The following is a description of a gene set: Genes having at least one occurrence of the motif NTGACTCAN in the regions spanning 4 kb centered on their transcription starting sites. This matches the JUN transcription factor binding site V$AP1_Q6_01 (v7.4 TRANSFAC). studied in species Homo sapiens Human Gene Set: AP1_Q6_01, and this is the list of marker genes: GJB3, NFRKB, SYNGR1, ABHD4, CSMD3, SPATA16, ESRRG, ANK3, SDCBP, ABCA2, PSMD7, AXIN2, MAP7D1, PDAP1, SYN1, DYRK1A, ASS1, SMPX, DTNA, AKT1S1, BRD2, TAGLN2, SNCG, STARD13, NRN1L, PSMA3, GAPDH, NFATC4, RCAN2, ITPKC, DCTN2, ZFYVE9, PDGFRB, S100A5, SPTA1, ITM2B, CAB39, ZNF207, GAST, KDM3A, PRSS22, PSMD2, MAGED1, TBC1D17 (NCBI Gene Id 79735), FBXO44 (F-box protein 44), LONRF3, IQCF1, PPP1R15A, LINC02908, LMNA, LAPTM5, HCLS1, ABCB6, CTNNAL1, GABBR1, RBBP7, KCNH2, ELK3, SV2A, NR0B2, EYA1, SCEL, IL9, RAB30, TOB1, UBE3A, PSMD12, SBSN, TRAPPC3, BUD31, VAT1, RNF144B (ring finger protein 144B), IGSF8, RAP1GAP2, DMPK, C1QTNF8, MCTP1, ADAMTSL1, ATP6V1A, TIAL1, PSME4, TENM3-AS1, MPRIP, LRRN4CL, DDIT3, RPL23A, KBTBD8, RIMS1, UBQLN1, LMOD3, PITPNC1, GIT2, CRYGS, AP2A2, HOXA11, ALDOA, LAMC1, TEX19, HSPA9, PLA2G2E, MAP4K5, MPV17, ASB5, EPHA2, VAPA, PI15, HSPG2, CLC, KCNA2 (potassium voltage-gated channel subfamily A member 2), GIT1, DIAPH1, GJA1 (NCBI Gene Id 7953), LPP, CAPN6, ZNFX1, RGS2, CASK, SNPH, DCN, ZBTB43, RTL9, ZNF771, PTPRR, LRRC2, MYOZ2 (myozenin 2, NCBI Gene Id 53348), AK5, NDUFA13, MMP19, DCLK1, PHLDA2 (NCBI Gene Id 7262), ANKRD22, CNTD1, NRDC, UCN2, KLK12, TRPV3, HSPB7, FERMT3, TNXB, PKN3, SCRN1, IRAK1, FGF9, ORAI1 (ORAI calcium release-activated calcium modulator 1), TUBA4B, CLSTN3, ROCK2, PPP2CA, KRT25, SMARCA2, EFNA1, PCDH9, PKP3, KRT86, TUBA4A, PAK6, EIF4G1, CCDC120, TBC1D10B, MAP4, ABCD1, FABP4, EEF1A2, XIRP1, GAB2 (GRB2 associated binding protein 2), OMG (NCBI Gene Id 4974), PTPRH, DUSP13B, LINC00649, TENT5A (NCBI Gene Id 55603), RBPJ, NUDT10, ZBTB32, RNF145 (NCBI Gene Id 353159), IDS, TNRC6A, IL1RN, DENND1B, VAMP5, IL6, CSNK1A1, OLR1, NRIP3 (NCBI Gene Id 56675), TMEM95, VCL, VGF, ELAVL2, SLC11A1, SLC26A9, BTK, RBM39, BDKRB2, LRP1B, TRAK2, NUDT11, PRDM1, MAP2, CAVIN3, ZNF385B, EPHB2, PIM1, GPX1, TNFRSF9, ZNF516-DT, EPN3, SQSTM1, PACSIN3, TMEM156, APOBR, CAPNS1, PPP2R2C, USP13, NOTCH4, GRIA1, STAT5B (NCBI Gene Id 6777), NECAB3, ATXN7L2, SNAP25, MDFI, TFE3, SEC24D, TRIM47, VIL1, FLNC, GGN, SYT2, NDP, KCNK10, ABI3, KLHL40, SEMA6B, SLC26A1, NUAK1, GADD45G, ZFAND5, VWA7, ANXA7, NAA50, CPNE8, MAP1A, SCAMP1, YIF1A (NCBI Gene Id 10897), REXO2, CCDC50, PIANP, SNX10, GABARAPL1, RB1CC1, FBRS, MAPK3, DDX17, METTL6, TLL1, SGK1, TUBA1C, DMKN, LRRFIP2, CHST1, ADGRF2P, FBXW11, EAF1, TSKU, EPB41L1, TRIM8, CAPN12, SRPK2, MYB